The following is a description of a gene set: Mouse Gene Set: GOMF_VOLUME_SENSITIVE_CHLORIDE_CHANNEL_ACTIVITY Enables the transmembrane transfer of a chloride ion by a volume-sensitive channel. A volume-sensitive channel is a channel that responds to changes in the volume of a cell. studied in species Mus musculus, and this is the list of marker genes: Ttyh1, Ttyh2, Ttyh3, Clcn3, Clcn2